The following is a description of a gene set: from publication Chen Y, Wang X (PMID 31504780) studied in species Mus musculus Genes predicted to be targets of miRBase v22 microRNA mmu_miR_7085_3p in miRDB v6.0 with MirTarget v4 prediction scores > 80 (high confidence targets). Mouse Gene Set: MIR_7085_3P, and this is the list of marker genes: Map7, Sdk1, Fam107a, Ntng1, Garre1, Fam193a, Tnfrsf9, Cbfa2t3, P2rx3, Clic5, Igfbp4, Med26, Ift52, Hook3, Gtpbp2, Vwc2l, Cpeb1, Mss51, Spag17, Atp2b3, Ndp, Akr1c20, Hif1a, Nfatc2, Hbs1l, Gpr17, Upk1b, Fbxo45, Homer3, Sgcd, Insyn2a (NCBI Gene Id 627214), Rfng, Kcnab2, Slc13a3 (solute carrier family 13 (sodium-dependent dicarboxylate transporter), member 3), Mip, Gjd2, Serpinb8, Rps6kc1 (ribosomal protein S6 kinase polypeptide 1), Eda, Kcnj10 (NCBI Gene Id 16513), Foxo1, Megf11, Tmbim7, Tnpo2, Acot11, Ncoa1, Mindy3, Wiz, Ephb3, Col6a1, Abr, Bnc2, Gls, Igsf9b, Lsm14a (LSM14A mRNA processing body assembly factor), Stxbp5l, Jaml, Grsf1, Flna, Gria1, Tardbp